Given this list of marker genes Il36a, Il1f10, Il36b, here is a description of the gene set: part of: Interleukin-1 family signaling Reactome Pathway: Interleukin-36 pathway electronically inferred by orthology from the curated human pathway This event has been computationally inferred from an event that has been demonstrated in another species.<p>The inference is based on the homology mapping from PANTHER. Briefly, reactions for which all involved PhysicalEntities (in input, output and catalyst) have a mapped orthologue/paralogue (for complexes at least 75% of components must have a mapping) are inferred to the other species. species: Mus musculus